Given this list of marker genes MPIG6B, ZNF510, ZNF385B, RAB33A, ACSM1, RNF111, TFG, GRIN1, FAM120A, ZNF292, LARP1B, HOOK3, FAM3C, VGLL3, TMEM114, BBOF1, HP1BP3, TECRL, INO80D, NBPF3, DRAM2, HYCC2, ZMIZ1, SMARCA2, CLDN12, MMD, CP, ZFP64, ZSWIM6, APBB1, ZSCAN31, REEP3, ZNF215, SYNJ1, TARDBP, WFDC5, RAB29, TAF5, FAR1, RNF144B, RRAGC, HIC1, ZNF436 (zinc finger protein 436), TMEFF2, STAM, TXNDC8, IL17F, RBFOX1, BLTP3B, PAXIP1, FERMT2, ATP6V1C1, here is a description of the gene set: from publication Chen Y, Wang X (PMID 31504780) Genes predicted to be targets of miRBase v22 microRNA hsa-miR-144-5p in miRDB v6.0 with MirTarget v4 prediction scores > 80 (high confidence targets). species: Homo sapiens Human Gene Set: MIR144_5P